Given this list of marker genes SLC7A7, SLC38A4, SLC7A2, SLC38A1, SLC25A29, SLC6A12, SLC7A3, SLC1A3, SLC7A8, SLC7A9, SLC6A19, SLC1A6, SLC1A1, SLC7A5, SLC6A20, SLC6A6, SLC1A7, SLC38A3, SLC7A1, SLC7A10, SLC38A5, SLC38A2, SLC16A10, SLC36A4, SLC6A14, SLC43A1, SLC36A1, SLC1A5, SLC1A4, SLC3A1, SLC3A2, SLC43A2, SLC36A2, SLC7A11, SLC1A2, SLC6A15, SLC7A6, here is a description of the gene set: This pathway serves as collection of reactions categorized as SLC-mediated transport of amino acids. part of: SLC-mediated transmembrane transport Reactome Pathway: SLC-mediated transport of amino acids studied in species Homo sapiens